Given this list of marker genes AFF4, PPM1L, CENPI, B3GNT2, CNNM3, ANKIB1, ESYT3, CCSER1, ATOSB, POU2F1, KLF4, TNFAIP2, GSTO2, ATRN, TOMM6, ATP8A1, NSFL1C, DSTYK, HACD2, ARPC2, JADE2, NR3C1, LRRIQ3, PNP, SLAMF8, ABI2, ATP5MK, CAPS, PRKD1, SLC16A2, ANTXR1, EVA1A, CNGB3, ADGRF5, XCL1, POU2F3, CHRNA9, ACSL5, CD44, MITF, LARP4, MTOR, CSRP1, ITSN2, HSD17B8, MAFB, MAP1A, CDCA2, FGF20, TTC9, ATXN7L3B, GPC4, CDS2, ITGA11, TACC2, CLCC1, FBXO32, IMMP2L, SKAP1, SMARCA1 (SWI/SNF related, matrix associated, actin dependent regulator of chromatin, subfamily a, member 1), RELN, here is a description of the gene set: Genes predicted to be targets of miRBase v22 microRNA hsa-miR-8059 in miRDB v6.0 with MirTarget v4 prediction scores > 80 (high confidence targets). Human Gene Set: MIR8059 studied in species Homo sapiens from publication Chen Y, Wang X (PMID 31504780)